The following is a description of a gene set: Human Gene Set: GOBP_POSITIVE_REGULATION_OF_SYNCYTIUM_FORMATION_BY_PLASMA_MEMBRANE_FUSION Any process that increases the frequency, rate or extent of the formation of a syncytium, a mass of cytoplasm containing several nuclei enclosed within a single plasma membrane, by the fusion of the plasma membranes of two or more individual cells. species: Homo sapiens, and this is the list of marker genes: FLOT1, IL4R, CCL8, TYROBP (NCBI Gene Id 7305), CXCL9, CAPN2, EHD2, SCGB3A1, TREM2, RAPGEF3, DCSTAMP, CD53, GCM1 (NCBI Gene Id 8521), MAPK14, ADGRB1, ADAM9, MYOD1, NFATC2, RIPOR2, CAMK1 (calcium/calmodulin dependent protein kinase I), OCSTAMP, EHD1, TNFSF14, GDF15